The following is a description of a gene set: studied in species Mus musculus Mouse Gene Set: GOBP_REGULATION_OF_BLOOD_VESSEL_REMODELING Any process that modulates the rate, frequency or extent of blood vessel remodeling, the reorganization or renovation of existing blood vessels., and this is the list of marker genes: Tmbim1, Flt4, Gja1, Cst3, Il18, Hrg, Lrp1 (NCBI Gene Id 16971), Abr (active BCR-related gene), Bcr, Ceacam1 (CEA cell adhesion molecule 1)